The following is a description of a gene set: studied in species Homo sapiens Human Gene Set: HOWARD_MONOCYTE_INACT_MONOV_INFLUENZA_A_INDONESIA_05_2005_H5N1_AGE_18_49YO_1DY_DN BACKGROUND: Vaccine development for influenza A/H5N1 is an important public health priority, but H5N1 vaccines are less immunogenic than seasonal influenza vaccines. Adjuvant System 03 (AS03) markedly enhances immune responses to H5N1 vaccine antigens, but the underlying molecular mechanisms are incompletely understood. OBJECTIVE: We compared the safety (primary endpoint), immunogenicity (secondary), gene expression (tertiary) and cytokine responses (exploratory) between AS03-adjuvanted and unadjuvanted inactivated split-virus H5N1 influenza vaccines. In a double-blinded clinical trial, we randomized twenty adults aged 18-49 to receive two doses of either AS03-adjuvanted (n = 10) or unadjuvanted (n = 10) H5N1 vaccine 28 days apart. We used a systems biology approach to characterize and correlate changes in serum cytokines, antibody titers, and gene expression levels in six immune cell types at 1, 3, 7, and 28 days after the first vaccination. RESULTS: Both vaccines were well-tolerated. Nine of 10 subjects in the adjuvanted group and 0/10 in the unadjuvanted group exhibited seroprotection (hemagglutination inhibition antibody titer > 1:40) at day 56. Within 24 hours of AS03-adjuvanted vaccination, increased serum levels of IL-6 and IP-10 were noted. Interferon signaling and antigen processing and presentation-related gene responses were induced in dendritic cells, monocytes, and neutrophils. Upregulation of MHC class II antigen presentation-related genes was seen in neutrophils. Three days after AS03-adjuvanted vaccine, upregulation of genes involved in cell cycle and division was detected in NK cells and correlated with serum levels of IP-10. Early upregulation of interferon signaling-related genes was also found to predict seroprotection 56 days after first vaccination. CONCLUSIONS: Using this cell-based systems approach, novel mechanisms of action for AS03-adjuvanted pandemic influenza vaccination were observed. TRIAL: ClinicalTrials.gov NCT01573312. Genes down-regulated in monocyte 1d vs 0d in adults (18-49) after exposure to inactivated monovalent influenza A/Indonesia/05/2005 H5N1 split-virus vaccine, time point 1D, administered i.m. from publication Howard LM, Hoek KL, Goll JB, Samir P, Galassie A, Allos TM, Niu X, Gordy LE, Creech CB, Prasad N, Jensen TL, Hill H, Levy SE, Joyce S, Link AJ, Edwards KM (PMID 28099485), and this is the list of marker genes: SYT17, QPRT, ZNF519, SNORA66, COLEC12, FCER1A, C1orf127, SRGAP3, ESAM, GATM, CD2, ITGA9, CTSF, AZU1, SIDT1, COL9A2, CDCA7, HSPG2, FCGBP, C16orf74, WFS1, PRRT4, SPNS3, KLHL30, LGI4, KCNJ5-AS1, IL1R1, PLD4, PCGF2, PRPF31, MYB, SNAI1, CKB, DTNA, AFF3, LPL, STARD13